Given this list of marker genes Agps, Pex7, Far1, Chpt1, Plaat3 (NCBI Gene Id 98147), Gnpat, Peds1, Nceh1, Plaat1, Lpcat2, Pxmp4, Dhrs7b, Pla2g7, Pla2g4a, Fasn, Pla2g6, Lipe, Tmem86b, Pla2g5, Pla2g10, Pla2g4c, Agmo, Selenoi, here is a description of the gene set: Mouse Gene Set: GOBP_GLYCEROL_ETHER_METABOLIC_PROCESS The chemical reactions and pathways involving glycerol ethers, any anhydride formed between two organic hydroxy compounds, one of which is glycerol. species: Mus musculus